Given this list of marker genes PLCB2, SFN, TNFRSF11B, F3, DVL1, TGFA (NCBI Gene Id 7039), TNNT3, CDH2, RND3, UGT8, CCL20, RPS6KA2, NOS1, CASR, HMOX2, RBMY1A1, LGALS4, OMG, NFKBIL1, CYP2D6, TMSB15A, ACSM3, CHRNB2, WFDC2, GRIK1, COL3A1, KYNU, EPHB1 (NCBI Gene Id 2047), NOVA1, MLC1, CETP (cholesteryl ester transfer protein), CP, DHRS2, TIMP4, LRRC32, SYT1, PTPRS, GLRA2, MEOX1 (NCBI Gene Id 4222), GRP, KLRC1, PIK3CD, P2RX1, TCP10L3, VSNL1, ITIH3, KRT86, CALML3, IL3, GRB14, DPP6, CRHR2, RAPGEF1, NNAT, CDKN2A, NMU, CXCL2, ALDH3A2, EFNA5, SPARCL1, POU3F1, ASGR2, TRIM29, CYP1B1, PDK4, DPEP1, GABRB3, CYP3A7, NAT2, ACR, DPP4, GAP43, FHL2, ROR1, QPCT, WASF3, FPR1, GPC3, GPX3, KLHDC3, ANGPT1, NPTX1, KRT4, KIR2DL4, PTPRG, GBP1, CCL4, SDS, NELL1, TYR, TNP1, UMOD, RGS7, MYH2, C7, COL4A2, SERPINA7, CD163 (NCBI Gene Id 9332), CHI3L2, THBS1, TCF15, IGF2, COL15A1, S100P, SRPX, SCTR, RGN (NCBI Gene Id 9104), NRG1, HRK, SERPINA6, FUT7, KLF5, POU2F2, DAO, LUM, PPP3CA, TFPI2, COL5A2, PAX5, PROCR, TGM3, NEO1, PAH, MFAP5, GJB1, EDA, PTPRO, CAV1, PRKCQ, ITIH2, PTH1R, CBLN1, CHGB, ITGA3, ISL1, RCVRN, FABP4, PMEL, NTSR1 (neurotensin receptor 1), SIM2, RREB1, EHHADH, COX7A1, ANK3, GATM, RBP4, RBP1, ZNF143 (NCBI Gene Id 7702), ADCYAP1R1, APOH, CPS1, ETV3, SCN4A, MYBPC1, PLXNB1, ALOX15, PTPRR, CXCL3, C1R, S1PR1 (sphingosine-1-phosphate receptor 1), GSTM3, A2M, MIR9-1HG, JAK3, TYRP1, BAAT, CYP2B6 (cytochrome P450 family 2 subfamily B member 6), APLP1, DEFB1, PRSS8, CDH17, KCNJ15 (NCBI Gene Id 3772), SLC34A1, SERPING1, C1S, OLFM1, MAOB, CLDN10, C5, AGXT, CDKN1C, MMP3 (NCBI Gene Id 4314), WT1-AS, SELENOP, MYOG, CRMP1, CYP2A7, CHGA, KIAA0040, ALDH3B2, GAD1, PRG4 (proteoglycan 4), RXRG, RIN1, NPY, MEF2C (myocyte enhancer factor 2C), ERCC8, DDC, THRB, SOX9, CEACAM1, ARSB, CD22, ADH1B (alcohol dehydrogenase 1B (class I), beta polypeptide), SCG2, BRME1, NEUROD1, CCL17, HPGD, UGT1A6, TSPAN8, GATA2, KRTAP5-9, CSF2RB, CEACAM5, DPYSL3, SMTN, UGT2B7, SLC28A1, UGT2B10, ATP1B2, EYA2, GSTM5 (glutathione S-transferase mu 5), ALDH1A3, PCP4, FCGR3A, RCAN2, ST6GAL1, PRTN3, EPAS1, KRT13, TNC, IGF1, PTPRD, NTRK3, GATA1, GRK5 (G protein-coupled receptor kinase 5), AMELY, PKIA, PSG6, AADAC, LY6D, SPRR1B, SLC1A3, CX3CR1, CTSK, KCNB1, AZGP1, TF, CYP2J2, ADRB2, GAS1, LAMA3, S100A5, THBS2, TCN2, NPY1R, AQP4, GPNMB, CSH2, here is a description of the gene set: Genes in the cancer module 112. studied in species Homo sapiens Human Gene Set: MODULE_112